Given this list of marker genes CYP1B1, EPHX2, CYP2C9, CYP2C19, CYP1A2, CYP2C8, CYP2J2, CYP1A1, here is a description of the gene set: Synthesis of epoxy (EET) and dihydroxyeicosatrienoic acids (DHET) Human Gene Set: REACTOME_SYNTHESIS_OF_EPOXY_EET_AND_DIHYDROXYEICOSATRIENOIC_ACIDS_DHET studied in species Homo sapiens